Given this list of marker genes COP1, COMMD4, DCAF17, FBXL15, PSMB5, FBXL19, FBXW2, COPS7B, KLHL41, ASB1, BTBD6, FBXL16, SQSTM1, DCAF5, CCDC22, SOCS3, PSMD13, ASB6, COMMD5, ELOB, EPAS1, PSMB1, FBXL18, ASB13, CCDC8 (coiled-coil domain containing 8), ASB11, ASB3 (ankyrin repeat and SOCS box containing 3), UBA3, DDB1, LRR1, BRCA1, FBXO44, UFD1, UBXN7, PSMC5, ASB5, TULP4, PSMD2, UBE2F, HIF1A, UBB, SEM1, PSMC2, FBXO6, RBBP7, FBXL20, FBXL4, COMMD9, FBXO32, ASB8, NAE1, DCUN1D4, WSB2, PSMA4, KCTD7, COMMD1, FBXW11, FBXW12, CAND1, PSMC4, COMMD7, COPS6, FEM1C, ZBTB16, SPSB1 (NCBI Gene Id 80176), WSB1, DCUN1D3, FBXL13, PSMB7, FBXO9, RNF7, VHL, FBXO11, FBXO41, COMMD6, CUL4A, DCUN1D2 (NCBI Gene Id 56234), PSMD3, WDR5, DCAF11, PSMB2, NEDD8, PSMA7, ASB14, SKP2, COPS8, UBE2D1, PSMB3, CISH, CUL3, PSMA2, SPSB2, HIF3A, NUB1, ASB9, CDKN1A, UBE2D2, FBXO2, FEM1B, FBXL5 (F-box and leucine rich repeat protein 5), PSMC6, SKP1, PSMC1, DCUN1D1, KLHL11, ERCC8, SOCS2, CUL9, FBXO27, FBXW4, FBXL7, FBXO31, NEURL2, COMMD8, PSMA3, PSMD14, KBTBD6, ASB7, SOCS5, COPS4, CUL5, FBXO40, CUL4B, AMER1, UBC, ASB17, DCAF7, SOCS6, FBXL14, FBXW9, PSMD1, ASB15, CUL7, DTL, OBSL1, ASB18, PUM2, FBXW8, FBXW7, CUL1, PSMB6, RBBP5, DCAF13, BIRC5, FBXO4 (F-box protein 4), DCAF8, FEM1A, ELOC (NCBI Gene Id 6921), GPS1, UBE2M, UBD, VCP, RBX1, DCAF16, PSMD8, KLHL42, DCAF4, WDTC1, FBXO22, FBXL12, NFE2L2, COPS7A, PSMC3, UBE2D3, PSMD7, ASB4, PSMD11, COPS2, PSMA1, FBXO17, RPS27A, SPSB3, KLHL3 (kelch like family member 3), FBXO21, ANKRD9, KLHL20, FBXO30, COMMD2, PALB2, FBXW10, COPS5, ASB2, KLHL9, NPLOC4, UCHL3, SENP8, LRRC41, KLHL21, GAN, COMMD3, DCUN1D5, KLHL2, FBXL22, DDA1, DCAF6, KBTBD13, ASB10, DCAF10, FBXW5, BTRC, PSMA5, FBXO10 (F-box protein 10), MUL1, CUL2, PSMD12, KLHL25, UBA52, SPSB4, PSMB4, KCTD6, CCNF, KBTBD8, FBXL8, KEAP1, PSMD6, KBTBD7, KLHL13, LMO7, BTBD1, ASB12, KLHL22, ASB16, FBXL3, COPS3, COMMD10, PSMA6, DPP3, FBXO7, FBXO15, DDB2 (damage specific DNA binding protein 2), ADRM1, KLHL5, here is a description of the gene set: Human Gene Set: REACTOME_NEDDYLATION Neddylation studied in species Homo sapiens